The following is a description of a gene set: A protein complex that stably associates with the C-terminus of RNA polymerase II and mediates 3'-end processing of small nuclear RNAs generated by RNA polymerase II. Human Gene Set: GOCC_INTEGRATOR_COMPLEX species: Homo sapiens, and this is the list of marker genes: NIPBL, INTS12, INTS13, INTS6L, INTS7, INTS3, INTS9, INTS4, INTS2, INTS14, INTS15, SEM1, INTS10, SAGE1, INTS11, ESRRB, INTS6, INTS5, INTS8, SAGE2P, INTS1